Given this list of marker genes VPS35 (NCBI Gene Id 91808), SNX5, ANKRD27, SNX6, VPS26A, here is a description of the gene set: A network of fine tubules in the vicinity of the Golgi complex and around the centriole. Human Gene Set: GOCC_TUBULAR_ENDOSOME species: Homo sapiens